The following is a description of a gene set: Human Gene Set: REACTOME_TRANSPORT_AND_SYNTHESIS_OF_PAPS species: Homo sapiens Transport and synthesis of PAPS, and this is the list of marker genes: SLC35B2, SLC26A1, SLC26A2, SLC35B3, PAPSS1, PAPSS2